The following is a description of a gene set: electronically inferred by orthology from the curated human pathway This event has been computationally inferred from an event that has been demonstrated in another species.<p>The inference is based on the homology mapping from PANTHER. Briefly, reactions for which all involved PhysicalEntities (in input, output and catalyst) have a mapped orthologue/paralogue (for complexes at least 75% of components must have a mapping) are inferred to the other species. Reactome Pathway: Interleukin-6 family signaling part of: Signaling by Interleukins species: Mus musculus, and this is the list of marker genes: Il6ra, Il6, Il31ra, Cntfr, Cntf, Clcf1, Cbl, Il11, Osm, Il11ra1 (interleukin 11 receptor subunit alpha 1), Il31, Lif, Tyk2, Ctf1, Crlf1, Osmr, Socs3